Given this list of marker genes HLA-A, HLA-C, CTSS, HLA-G, LNPEP, HLA-E, HLA-F, CTSV, HLA-H, HLA-B, B2M, CTSL, here is a description of the gene set: species: Homo sapiens Some antigens are cross-presented through a vacuolar mechanism that involves generation of antigenic peptides and their loading on to MHC-I molecules within the endosomal compartment in a proteasome and TAP-independent manner. Antigens within the endosome are processed by cathepsin S and other proteases into antigenic peptides. Loading of these peptides onto MHC-I molecules occurs directly within early and late endosomal compartments. Why certain antigens are cross-presented exclusively by the cytosolic pathway while others use the vacuolar pathway is unknown. It may be because some epitopes cannot be generated by endosomal proteolysis, or are completely destroyed. Alternatively, the physical form of the antigen may influence its accessibility to the endosomal or vacuolar pathways. Reactome Pathway: Endosomal/Vacuolar pathway part of: Antigen processing-Cross presentation